Given this list of marker genes PRRT2, DHFR, SCN2A, AP2M1, KCNQ2, SCN8A, KCNQ3, here is a description of the gene set: Human Gene Set: HP_EYELID_MYOCLONIA_SEIZURE Eyelid myoclonia seizure An eyelid myoclonia seizure is a type of generalized myoclonic seizure which may or may not be associated with loss of awareness. species: Homo sapiens